The following is a description of a gene set: Biological oxidations Human Gene Set: REACTOME_BIOLOGICAL_OXIDATIONS species: Homo sapiens, and this is the list of marker genes: PAOX, AKR7A2, CYP4F2, GSTA5, CYP7B1, CYP2C8, ALDH1A1, FDXR, GSS, CYP46A1, GGCT, BPNT2, SLC35B2, MTARC2, ADH4, N6AMT1, RXRA, GCLC, POR, CYP4F8, BPHL, FDX2, NNMT, UGT2A2, GSTK1, TRMT112, UGT1A1, AOC1, MAT2A, CES1, CYP21A2, CES3, CYP8B1, CYP26C1, CYP2E1, GSTA4, CYP39A1, GCLM, HPGDS, ADH7, CYP2S1, ADH1B, GSTA1, AKR7L, SULT1A4, AKR7A3, ACSM5, GSTA3, CYP3A4, UGT2B10 (NCBI Gene Id 7365), UGT2A3, CYP2U1, CYP4A11 (cytochrome P450 family 4 subfamily A member 11), GSTM4, CYP1A1 (cytochrome P450 family 1 subfamily A member 1), MTRR (NCBI Gene Id 4552), FMO2, CMBL, CYP4F12, NR1H4, ACY1 (NCBI Gene Id 95), CYP11B1, EPHX1, SULT1C4, POMC, ACSM2A, CYP2B6, CYB5R3, CYP4F22, FDX1, SULT2B1 (NCBI Gene Id 6820), CYP4A22, UGT1A3, GLYAT, ACSS1, UGT1A4, CYP4F3 (NCBI Gene Id 89256), ADH1A, CYP7A1, SLC26A1, UGP2, GSTT2, CYP11A1, FMO3, UGT3A1, AS3MT, UGT2B11, CYP2C19, CYP2A6, CBR3, NCOA2, CYP1B1 (NCBI Gene Id 1545), CYP3A5, UGT2B17, CHAC2, UGT1A8, MGST3, CYP4B1, HSP90AB1, GGT7, ADH1C, TPST2, PTGES3, PTGS1, GSTA2, CYP2W1, NAT1, UXS1, UGT1A6, SLC35D1, AOC2, SULT1E1, CYP51A1, ABHD10, GGT1, ESD, NCOA1, GSTM5, CYP11B2, MTR, ALDH3A1, UGT1A5, CYP27A1, UGT2B15, MAOB, AOC3, GLYATL2, GSTM1, GSTM3, GLYATL3, GSTM2, UGT3A2, PTGIS, ARNT, ACSM1, PAPSS2 (3'-phosphoadenosine 5'-phosphosulfate synthase 2), FMO1, GLYATL1, CYP2J2, TBXAS1, MAT1A, GGT6, SULT1C2, SULT1A2, ADH5, TPST1, CES2, GSTT2B, GSTP1, CYP3A7, SULT2A1, UGT2B4, AHR, CYP27B1, CYP1A2, TPMT, SMOX, SULT6B1, MGST2, GSTO1, PAPSS1, CYP24A1, CYP4F11, UGT2A1, CYP2A13, CYP26B1, AIP, SULT1B1, ADH6, ACSM2B, UGDH, ARNT2, CYP2C9, NAT2, AADAC, SLC35B3, CYP3A43, ALDH1B1, GSTO2, UGT2B7, UGT1A10, SULT1A1, AHCY, GSTT1, ACY3, DPEP2, GGT5 (gamma-glutamyltransferase 5), SULT1A3, UGT1A9, ALDH2, ACSM4, MAT2B, CYP2R1, CYP2C18, ACSS2, AKR1A1, SLC35D2, MTARC1, CYB5B, MAOA, UGT1A7, DPEP1, COMT, CYP2F1, SLC26A2, OPLAH, MGST1, UGT2B28, SULT4A1 (sulfotransferase family 4A member 1), CHAC1, PODXL2, CYP26A1, NQO2, CYP4V2 (cytochrome P450 family 4 subfamily V member 2), CYP2A7, CYP2D6, ABHD14B, GSTZ1, CYP19A1, CNDP2, BPNT1